The following is a description of a gene set: studied in species Homo sapiens Human Gene Set: HP_FRONTOTEMPORAL_CEREBRAL_ATROPHY Frontotemporal cerebral atrophy Atrophy (wasting, decrease in size of cells or tissue) affecting the frontotemporal cerebrum., and this is the list of marker genes: TMEM106B, GABRA5, GRN, COG4, PLA2G6, SQSTM1, IFT56, PRKAR1B, ATP1A3, TREM2, CHMP2B, PSEN1, VCP, MAPT, HSD17B10, SPG21